The following is a description of a gene set: species: Mus musculus A process that is carried out at the cellular level which results in the assembly, arrangement of constituent parts, or disassembly of a lipid particle. Mouse Gene Set: GOBP_LIPID_DROPLET_ORGANIZATION, and this is the list of marker genes: Pla2g4c, Spart, Sqle, Ldah (lipid droplet associated hydrolase), Ptgfrn, Cidec, Clstn3, Ddhd2, Cideb, Pisd, Bscl2, Ppid, Pnpla3, Cds2, Kat5, Prkaa2 (NCBI Gene Id 66516), Mospd2, Negr1, Smim22, Plin3, Ldaf1, Ppia, Rab18 (NCBI Gene Id 19330), Prkaa1, Zfyve1, Tspo2, Rab3gap1, Plin5, Fitm2, Pnpla2, Cds1, Plin2, Cidea, Rnf213, Chka, Faf2, Fitm1, Aup1, Tbc1d20